Given this list of marker genes LUM, HEXB, OGN, ACAN, PRELP, GLB1, OMD, GLB1L, GLB1L3, KERA, GALNS, GNS, FMOD, HEXA, GLB1L2, here is a description of the gene set: Reactome Pathway: Keratan sulfate degradation species: Homo sapiens part of: Keratan sulfate/keratin metabolism Keratan sulfate proteoglycans (KSPGs) are degraded in lysosomes as part of normal homeostasis of glycoproteins. Glycoproteins must be completely degraded to avoid undigested fragments building up and causing a variety of lysosomal storage diseases. KSPGs are Asn-linked glycoproteins and are acted upon by exo-glycosidases to release sugar monomers. The main steps of degradation are shown representing the types of cleavage reactions that occur so the full degradation of KS is not shown to avoid repetition. The proteolysis of the core protein of the glycoprotein is not shown here.